Given this list of marker genes GOLGA2, MDC1, CIAPIN1, APMAP, SNED1, PCCB, FAM114A2, H4C3, GTF3C1, ZNF22, CX3CR1, CEP250, MAP3K12, ATM, LANCL2 (NCBI Gene Id 95548), MPHOSPH9, SCCPDH, TLL2, AQP6, HOXB9, DAPK2, ABCF1, PRKAR1B, MT1F, SLC14A1, ZBTB32, FOXC1, KIAA0753, LRRC3, TMED1, SEMA6C, LARS1, INTS14, RPGR, PTCH1, BRD3OS, PRR36 (proline rich 36), SREBF1, OVGP1, SUGCT, PECAM1, SPG11 (NCBI Gene Id 80208), DCLRE1C, SH3BP2, TBC1D1, PUS7L, UBQLN4, PARP16, ACY1, TSPAN32, ATP8B1, FOXA2, TRNAU1AP, GZMH, TCF7, FAM135A, C2CD3 (NCBI Gene Id 26005), FOXH1, LRIF1, CACNA2D2 (calcium voltage-gated channel auxiliary subunit alpha2delta 2), SFSWAP, VNN2, KLRC4, IPP, HSD17B8, GSE1, TCF3, ACSF2, IVD, CARD9, PTCD2, IP6K1, XDH, TARP (NCBI Gene Id 445347), NRCAM, DOCK3, SULT1B1, PAK4, CSDC2, TENT5A, EIF4G3, MYBL1, LRRN3, CUX1, CCHCR1, GPR182, PDGFRB, ADAP1, SH3BP4, KLRC3, SLC5A3, HAUS2, MRPL41, PKD2, PGF, RALBP1, DYSF, PRRG4, PTPRO, GOLGA8H, GZMK, PDX1, ZNF232, MCM2, NEK1, CORT (NCBI Gene Id 1325), OGFOD1, FBXW12, GMIP, FCGBP, SPOP, CD248, CD8B, ZDHHC24 (zinc finger DHHC-type containing 24), OSGIN1, PADI4, ZNF200, MFSD11, ATP8A1, SLAMF7, POLR1B, MED16, ZKSCAN7, GZMB, PRF1, DSC1, NPFFR1, NKG7, SIDT2, DHX32, NAT10, GTF2H3, TMEM97, ANAPC1, CD8A, PLEK, EPN3, PDE4C, PRR5, EI24, YBX3, LBH, NCR3, GTDC1, CHST12, PIAS4, TCF7L2, KLRK1, SLC35E1, SPATA7, KLRG1, DBT, DPP8, COL6A2, CBLB, NAA38, CCDC69, CYP3A4, SIDT1, SDHAP1, CYP2A13, ZNF721, HNF1B, CPZ (NCBI Gene Id 8532), SYTL2, MATK, NELL2, ZFTA, GALNT11, EMX1, CRTAM, NUCB2, TSPOAP1, GAS1, PPT2, CHD9, SCN2B, ADRB2, CD79A, CD160, POLM, PRKAG1, UROS, BTK, CCDC86 (NCBI Gene Id 79080), C12orf43, AGAP1, HOMER1, NPFF, ZNF91, WDR12, SYNGR1, P2RY13, WDR37, GSAP, here is a description of the gene set: Human Gene Set: GSE22886_NAIVE_CD8_TCELL_VS_MEMORY_TCELL_UP Immune cell-specific expression is one indication of the importance of a gene's role in the immune response. In order to identify such patterns, we set out to broadly profile gene expression in a variety of immune cells. from publication Abbas AR, Baldwin D, Ma Y, Ouyang W, Gurney A, Martin F, Fong S, van Lookeren Campagne M, Godowski P, Williams PM, Chan AC, Clark HF (PMID 15789058) Genes up-regulated in comparison of naive CD8 T cells versus naive CD4 CD8 T cells. species: Homo sapiens